Given this list of marker genes PRKCE, ZFC3H1, FEM1B, DEPTOR, NUS1, LHX1, SEPTIN9, MAP3K3, B4GALNT1 (beta-1,4-N-acetyl-galactosaminyltransferase 1), SLC33A1, WIPI2, DCUN1D3, SINHCAF, OR10W1, NEK7, BRINP2, LRRC3, PDZRN4, TMEM169, DLEU7, ZHX2, TMEM198, SPEN, QKI, POU2F2, SERINC5, UBE2Q2, PPP4R3A, ZDHHC17, SLC12A5, SLC44A2, ACTRT3, KLHL34, PDE8B, NTN4, SLC39A9, ZCCHC3, EVI5, CNNM3, VAT1, GAP43, ATXN3, BICRAL, RGS2, AK3, EDEM1, UNC13C, CRYGS, MAP2K3, RAB10 (NCBI Gene Id 51140), SPRY3, RGPD1, PLCB4, DLAT, RAB27A, ANKIB1, RARG (NCBI Gene Id 5916), CNOT6L, CAV1, CREB3L2, AGO4, LILRA1, MORF4L2, SPAG8, ARHGAP6, TNS3, FOXK2, CHST1, FRS2, MAST4, RNF139, SH3PXD2B, RELL1, OGT, OVOL1, LRIG1, LAMC1, ST6GALNAC3 (ST6 N-acetylgalactosaminide alpha-2,6-sialyltransferase 3), PPP1R9B (protein phosphatase 1 regulatory subunit 9B), MAK, KLHL4, RITA1, EPAS1, RICTOR, GALNT2, ATG9A, ABCD1, PRRT3, STX5 (syntaxin 5), NCKAP1, KIAA1217, PLAGL1, PRDM16, TRIM9, SPIN1, TAF4B, MITF, CERS2, FKBP7, MRAS, LRRC7, TPR, RAB35, JPT2, STK17B, IGF2BP1, RAPGEF4, MTDH, TTYH3, NCALD, PHF20L1, KPNB1 (karyopherin subunit beta 1), ANKRD52, KCNG3, USP45, DMXL1, LRRC28, PRRG3, FAM43A, ZBTB41 (NCBI Gene Id 360023), ZFHX4, ZEB1, E2F5, ARHGEF3, TRIM46, CORO1C, LRRC4, RUNDC3B, TRIB3, PYGO2, NOVA2, LRCH2, CACNB4, ADGRL2, KIAA0513, SLC24A4, BRWD3, NRN1, CHIC1, SLC12A6, USP5, B3GNT2, FOXF2, USF3, SESN3, ADD3, RAB3C, ST7, SLC18A3, ARHGEF12, YWHAG, KRAS (NCBI Gene Id 3845), ADCY6, MORF4L1, AP3S1, SH3KBP1, PTP4A1, WDR82, PAIP1, PPP3CA, PLPPR4, PRRX1 (paired related homeobox 1), ABCA2, RNF183, PAFAH1B1, ITPR1, DOCK9, HAS2, KLHL7, GPR135, PNPLA1, AJAP1, RAB8B, ABHD13, LPP, MTCL2, AZIN1 (antizyme inhibitor 1), BRPF3, RAB2A, MFAP3, OXSR1, CPSF6, DHX8, SOX5, SLC26A9, LMTK2, SLC7A8, TMEM170B, SLC16A9, RIOX1, PRTG, GRB2, GIT2, FNDC3B, GXYLT1, HOOK3, CNTN1, FYCO1, MAP2K1, HDAC7, OLFM1, MAP1B, YIPF4, L1CAM, MCMBP, TCF7L2, SERPINB2, SLC22A5, ERG, TOPORS, FAM171A1, ZNF704, EPHA3, EIF4EBP2, BNC2, NLGN2, MAGEL2, NANOS1, EBF3, ASTN1, ASH1L, FOXO3, ARPP19, AHR, EXT1, CADM2, ANXA11, RALB, NPTX2, ZHX1, NUDT13, BCR, LMTK3, MFAP3L, THBS2, RBM20, SIN3B, ATG16L1, TUT4, FGF9, DPYD, ARPC5L, MROH2A, ATP2B4, SH3BP5, PHIP, RAB23, ERC2, GDNF (NCBI Gene Id 2668), CBFA2T3, ADK, MIGA1 (NCBI Gene Id 374986), LNX2, DAAM1, GAN, BMPR1B, SNX16, XKR4, RALGPS1, TAPT1, SPAST, GLE1, STK19, CEP170B, HSPA2, CNN3, JMJD1C, ALK (ALK receptor tyrosine kinase), CD164, MTOR, CYRIB, SV2C, PHAF1, RWDD4, SLC44A5, PAK1, PURA, TBR1, OXGR1, ELOVL5, CELSR2, SMAD1, KCNK9, GPR22, CDH20, PIK3C2A, COL25A1, SLAIN2, FOXO1, PTPMT1, ATXN1, BRMS1L, PLOD2, GNAI3, NEUROD4, UCK2, ANKRD27, SCML4, MAP3K2, SLC38A4, ITPR2, PDZD8, SLC1A1, SEZ6L, ELAVL4, DOCK1, MTHFD2L, UBE2G1, VAT1L, IGF1R, EIF5, FN1 (NCBI Gene Id 2335), ZFAND5, STMND1, VAMP3, TLL1, CRKL, CLN5, PPM1L, RPS6KA6, SPSB1, LCP1, CTDSP1, PPP3R1, STAG1, PHYHIPL (NCBI Gene Id 84457), EOMES, MTSS1, MYRIP, PCGF5, SLF2, FARP1, TARBP1, PRKAR1A, SOX6, MED1, TAC1 (NCBI Gene Id 6864), PPM1F, ADGRB3, RGS17, CACNA2D2 (NCBI Gene Id 9254), DPY19L3, CHST10, C5orf22, GPC3, REV1, SNX30, ZCCHC14, PHACTR4, SLC39A1, PGAP1, EIF3J, SDC2, AEBP2, APPL1, PALLD, FRMD5, SORT1, PTGER3, PPIL1, NOVA1, RASSF8, STK17A, REPS2, DCUN1D1, BCL2L12, DOCK4, CTTN, MED14, PRIMA1, SLC6A9, FOXQ1, LGI1, TOX, ERLIN1, GCNT1, MSN, HOXA9, COL13A1, YES1, GBP5, DNAAF9, SLITRK4, DDAH1, HBEGF, DEUP1, AQP2, ZFP36L1, SCYL3, NEXMIF, IRS1, here is a description of the gene set: Genes predicted to be targets of miRBase v22 microRNA hsa-miR-1271-5p in miRDB v6.0 with MirTarget v4 prediction scores > 80 (high confidence targets). studied in species Homo sapiens Human Gene Set: MIR1271_5P from publication Chen Y, Wang X (PMID 31504780)